Given this list of marker genes BRIP1, KAT5, BLM, DNA2 (NCBI Gene Id 1763), XRCC2, TOP3A, RAD51D (RAD51 paralog D), RMI2, RAD51AP1, EXO1, ATM, RTEL1, RAD50, BRCA2, RBBP8, RAD51, MRE11, RAD51B, BARD1 (BRCA1 associated RING domain 1), RAD51C, XRCC3, WRN, RMI1, PALB2 (partner and localizer of BRCA2), BRCA1, NBN, SEM1, here is a description of the gene set: studied in species Homo sapiens Reactome Pathway: Resolution of D-loop Structures through Synthesis-Dependent Strand Annealing (SDSA) part of: Resolution of D-Loop Structures In the synthesis-dependent strand-annealing (SDSA) model of D-loop resolution, D-loop strands extended by DNA repair synthesis dissociate from their sister chromatid complements and reanneal with their original complementary strands, resulting in non-crossover products. SDSA is promoted by the DNA helicase RTEL1. Additional DNA synthesis occurs to fill the remaining single strand gap present in the reannealed DNA duplex. DNA polymerase alpha has been implicated in this late step of DNA repair synthesis, although RTEL1-mediated recruitment of PCNA-bound DNA polymerases may also be involved. The remaining single strand nicks are closed by DNA ligases, possibly LIG1 or LIG3.